Given this list of marker genes UBE2S, UBE2G1, TSG101, UBE2V1, UBE2K, UBE2A, UBE2I, UBE3C, UBE2N, UBE2D3, UBE2V2, UBE2D1, UBE2D2, UBE4A, CYB561D2, SUMO1, UBE2M, UBL4A (ubiquitin like 4A), UBE2E1, UBR5, UBA2, UBE2B, UBE2H, UBE2L6, here is a description of the gene set: studied in species Homo sapiens Human Gene Set: MODULE_82 Genes in the cancer module 82.